Given this list of marker genes PHGDH, IGFALS, ETS1, WNK1, IL6ST, NR2C2, KCNB1, SOD2, LALBA, QPCTL, RBBP4, GUSB, NFIC, XIST, OGT, HSD17B11, STAT5B, GPAM, MAP4K2, PCMTD1, CYGB, BPNT1, EPAS1, KDM5C, DDX6, HDLBP, YKT6, TAOK1, ADISSP, LASP1, DHX36, CSN2, SLC2A5, SLC25A10, IGHM, CPD (carboxypeptidase D), PRELP, BTN1A1, ACACA, ZFP91, GYS2, JAG1, ZBTB20, NFIL3, SLC2A4, LRATD1, MAPK8IP1 (NCBI Gene Id 9479), ATP8A1, WASL, HIPK2, CSN1S2AP, IGHA2, RAD23A, SEC61A1, JCHAIN, AKT1, GRB10, ARHGEF2, TBL1X, SH2B3, PPP2R5B, SORBS1, CRIM1, PI16, SNCG, SOX9, NDST1, RESF1, GALNT2, VAPB, LRP5, CORO1A, SIRPA, EIF4G1, MLXIPL, SFTPD, APLP2, TPR, ABCC3, EIF4EBP2, SMARCA4, AKAP9, PTEN, TRBC2, MAPK8, EPB41L2, LAMA4, SYNCRIP, ITSN2, CAVIN1, PIK3R1, NFATC3, FGG, AKT2, GYS1, MYO1C, EHD2, FADS2, PPP6R3, PANK3, TMEM143, CHI3L1, KCNK3, PCYT1A, TGFBR1, IP6K1, YWHAG, LIPG, TMEM45B (transmembrane protein 45B), KEAP1, IL6R, TPSB2, PRKACB, TCF7, DPYSL3, GM2A, EXTL3, RASSF3, TMEM79, CHD4, MEF2C, SLC38A10, NFIX, NORAD, TRAC, COMT, RAB5C, MS4A1, GID4, ATP6V0A1 (NCBI Gene Id 535), RUNX1, PRRX1, ZBTB7B, BRD8, SPPL2A, SOD3, UBTF, RAB5B, MAPK14, SECISBP2L, NFIB, TNS1, ANKH, TIMP2, EBF3, DNM2, KIF1C, QKI, MBTPS1, FZD4, EHD3, SFPQ, FTO, CLCA3P (NCBI Gene Id 9629), CANT1, PDCD6IP, CYTH1, STEAP3 (NCBI Gene Id 55240), GBP4, CSNK2A1, DAPK1, SCD, ZEB2, CP, FSCN1, KDM5A, IGKC, UBE4A, CLEC3B, ECM1, PTK2B, H3C15, BLTP2, BRD4, IGFBP4, PDAP1, PRPF19, ATP1A3, EHD1, EGLN1, SMC6, CA8, LCK, STOM, TYR, LIPA, IGFBP5, NRIP1, LPGAT1, EIF3C, CUX1, GPD1, ACLY, CCND2, SNTB2, OGFR, MALAT1, CNOT3, here is a description of the gene set: Human Gene Set: MCBRYAN_PUBERTAL_BREAST_6_7WK_UP Genes up-regulated during pubertal mammary gland development between week 6 and 7. from publication McBryan J, Howlin J, Kenny PA, Shioda T, Martin F (PMID 17486082) Expression microarray analysis identified over genes regulated during puberty in the mouse mammary gland. Most prominent were genes whose expression increased in parallel with pubertal development and remained high thereafter. Members of the Wnt, transforming growth factor-beta and oestrogen-signalling pathways were significantly overrepresented. Comparison to expression data from CITED1 knockout mice identified a subset of oestrogen-responsive genes displaying altered expression in the absence of CITED1. Included in this subset are stanniocalcin2 (Stc2) and amphiregulin (Areg). Chromatin immunoprecipitation revealed that ERalpha binds to oestrogen response elements in both the Stc2 and Areg genes in the mammary gland during puberty. Additionally, CITED1 and ERalpha localize to the same epithelial cells of the pubertal mammary gland, supporting a role for interaction of these two proteins during normal development. In a human breast cancer data set, expression of Stc2, Areg and CITED1 parallel that of ERalpha. Similar to ERalpha, CITED1 expression correlates with good outcome in breast cancer, implying that potential maintenance of the ERalpha-CITED1 co-regulated signalling pathway in breast tumours can indicate good prognosis. studied in species Mus musculus